The following is a description of a gene set: species: Homo sapiens Human Gene Set: GOCC_NUCLEAR_PROTEIN_CONTAINING_COMPLEX A stable assembly of two or more macromolecules, i.e. proteins, nucleic acids, carbohydrates or lipids, in which at least one component is a protein and the constituent parts function together in the nucleus., and this is the list of marker genes: PAXX, HNRNPA2B1, KAT8, GTF2A1, CDK13, INTS6, NELFE, RRP7BP, RNVU1-3, TESPA1, TAF1A, ANAPC2, FOS, CBX3, BCLAF3, ACTR8, RAD9A, MSH3, CSNK2A2, INTS14, CWC22, MLH1, GTF2E2, HNRNPDL, TAF9B, IRF9, THRA, TAF11L2, POLR1B, ORC5 (origin recognition complex subunit 5), DDX39B, GPKOW, CCNH, BASP1, POLR1A, OGT, TFPT, BOD1L1, POLR1E, PMS1, BRD9, DDX46, GLE1, COPS6, ORC1, POM121L2, MMS22L, PTGES3, WWOX, SSU72L4, DYNLL1, RBM47, ANAPC15, CSNK2A1, SF3B1, TAF11L3, NCR1, THRB, FOXH1, UIMC1, INO80D, TFIP11, MAFK, SMU1, GEMIN2, HSPA7, SNRPN, CLP1, FANCE, NXF2, ATRIP, MCM7, NXF5, GTF2H4, CSTF1, TOPBP1, TAF9, UTP6, TAF11L13, INTS3, ACTR6, EXOSC9 (exosome component 9), RFC3, IMP4, E2F5, RAN, HUS1, GPATCH1, JUNB, RNVU1-6, ATF3, CENPX, BAZ1A (bromodomain adjacent to zinc finger domain 1A), UXT, SSU72L2, ING2, PELP1, TRA2B, KMT2C, TCF15 (transcription factor 15), UBE2C, ATP23, UBE2S, NFYB, CDK2AP2, SMAD5, CEBPB (NCBI Gene Id 90277), SMARCAL1, U2SURP, CHMP1B, SHMT2, BCLAF1, LSM6, NXT1, MED27, MCRS1, JUND, POLD1, HEATR1, HNRNPF, DCAF1, TERC, GINS2, RGPD8, LEO1, RAMAC, JDP2, MSH6, CSNK2B, SMARCC2, CDC27, SSU72, HAVCR2, AMOT, HDAC1, AQR, PRMT5, ACTL6A, SLBP, PRPF40B, FZR1, TAF10, LSM3, SUV39H1, TERF1, MORF4L1, FAAP24, MIS18A, SYNE1, UTP4, ATF7, BPTF, SUN2, SLA (NCBI Gene Id 6503), PLCG1, SAMD11, ZNF217, ACD, MAD2L2, HDAC2 (NCBI Gene Id 3066), RBBP7, CPSF6, HSPA1A, UPF2, DHX40, DEK, THOC3, NUP54, ASCL3, ERCC6, SYNE4, SNIP1, SWI5, WEE2-AS1, POM121, ZNHIT1, SUPT5H, CPSF4, NUP205, DDX21, LUC7L, TAF11L12 (TATA-box binding protein associated factor 11 like 12), UPF1, YJU2, SYF2, RXRG, RAD9B, TUT1, BRCA2, NOC4L, HDAC6, BARD1, ATF5, INTS12, CPSF3, INO80, YY1AP1, LIG3, POLE3, TINF2, WAC, BCL11A, POLR2J, RFX5, UBAP2L, UBQLN4, KMT2A (NCBI Gene Id 79951), RBMY1J, MRNIP, SSU72L3, STAT6, GTF2A1L, RBMX, MX2, NKX2-5, POLR2A, THOC1, RBMX2, INTS7, STAT1, CHTF18, RBMY1D, CDC26, ATR, FLNA, TEAD2, POLR2H, UTY, RNU5D-1, SAP30, GRB2, TFDP1, CHMP4A, RNVU1-7, LGALS3, SSRP1, L3MBTL1, WBP4, HAND1, HDAC7 (histone deacetylase 7), RNVU1-4, JARID2, RGPD4, PPIH, DYDC1 (NCBI Gene Id 414183), TEN1, NIPBL, SNRNP200, CWF19L2, IPO5, SFR1 (SWI5 dependent homologous recombination repair protein 1), HDAC8, BACH2, NR5A2, BABAM2 (NCBI Gene Id 9577), XRCC1, MED20, TLE1, SLX4, ARFGEF1, SLU7, CECR2, EZH2, GATA4, ATF6, GCFC2, MIDEAS, RFXAP, RPP30, RBMY1B, MED7, SMAD3, COPS5, PBX1, RHEB, PAAF1, RPP40, AFF4, POLR3K, PRPF18, CHD3, TAF11L9, PHF5A, AHCTF1, SF3B2, RNU1-4, RYBP, RNU5F-1, HCFC1, SNRNP70, PHF19, YAP1, PNN, ASXL2, NUP88, MED15, WDR12, CEBPZ, PSMC5, SINHCAF, HNRNPH1, CSTF2T, INTS1, SF3B6, FLOT1, E2F4, RPA4, NOP14, TBL1XR1, MEPCE, CDC16, HDAC11, TAF1, RBM17, ZBTB7A, TRERF1, ELOA2, PPARGC1B, ERCC3, ACIN1, CREBZF, RPA3, AFF2, DNAJC17, SARNP, TAF2, BRCC3, SNRPD3, KDM3B, PHF21A, WDR6, XBP1, LSM2, EXOSC3, RFC2, C1D, GEMIN5, MED26 (NCBI Gene Id 9441), SRSF1, POLR2C, KPNB1, CDK2AP1, PPIL2, TERB1, TAF8, VDR, MYF6, RNU5A-1, TERT, PPIL1, RUVBL2, TXNL4A, RUNX1 (NCBI Gene Id 861), POLR3G, INTS11, DNTTIP1, PRIM2, SMARCD3, SNRNP35, BUB1B, MTA1, MED22, DEAF1, RNU5B-1, TDRD3, POLR3B, MAFB, CHTOP (chromatin target of PRMT1), RAD51, TET1, TBL1Y, SENP3, ASXL3, BICRAL, IMP3, GTF2H2, PRPF31, NUP155, SS18 (NCBI Gene Id 6760), SMARCA2, SNU13, REL, SF3A3, TCF7L1, NUDT21, MXI1, SKP1, TBL1X, RFC4, POLR3E, DQX1, RNF113A, BRMS1, GTF2E1, SSU72L5, GTF2B, PRPF19, THOC7, UBE2I, RAD1, HELB, TAF12-DT, TAF7, SNRPB, TAF4B, VPS4A, API5, RAD51B, CEBPD, CDK19, POLR2B, RXRA, CBFB (core-binding factor subunit beta), ZRSR2, SNRPD2 (NCBI Gene Id 6633), DDX19B, TBX15, SUN3, CDK7, BRIP1, DDX20, RNU4-1, RBMY1E, POLR1F, U2AF1, CPSF1, LIG4, CHMP4BP1, UBA2 (ubiquitin like modifier activating enzyme 2), KPNA3, POLR1H, CRIPT, NXF2B, POP1, MED18, SSU72L1, POLE2, BOD1, GTF2H5 (general transcription factor IIH subunit 5), POLR3A, RALY, TAF11L10, TAF3, SUPT6H, NUP107, RPP38, FANCL, THOC5, RNVU1-2A, APOBEC3F, POU4F1, NABP1, U2AF2, MAU2, NVL, NUP93, HLTF, KAT2A, ERI1, SENP2, EPB41L2, CHMP4B, FOSL2 (NCBI Gene Id 79579), NUP62, POLE4, SUN1, MMS19, ERCC1, HIPK2, HNRNPA1L3, ERCC8, COPS7A, XRCC4, MED12L, SETD1A, BCCIP, SIN3A, ZMAT5, LRWD1, INTS2, CACTIN (NCBI Gene Id 58536), TBX18, SUZ12, KANSL1, NUP188, NFE2L3 (NCBI Gene Id 9603), ANP32E, BCL9, POLR2I, IVNS1ABP, EIF4A3, WDR36, GRAP, RBM42, PRPF40A, DYDC2, INTS6L, SNUPN, MXD3, CETN3, ATF1, SMAD4, E2F1, NFATC2, PYM1, INIP, PYGO2 (pygopus family PHD finger 2), GTF2H1, CREB3, RGPD1, DDIT3, PRKRIP1, EXOSC2, MED17, RSF1, INO80E, TSEN34, ARID4A, ISY1, GNL3L, SNRNP27, ZNF335, PAF1, INTS13, CHMP5, ORC4, POLR2E, CTR9, NUP210, ATF6B, SNW1, INTS10, XAB2, CCDC9, SMARCA4, CFDP1, C9orf78, BCL7B, MED24, CBX4, TCF7, PHC2, CBX5, LEF1, SUN5, NFE2L2, TXNL4B, MAGOHB, HOXB9, SMAD1, SNRNP25, GTF2F2, NUP35, SF3B3, WRAP53, RGPD3 (NCBI Gene Id 692054), NEUROD1, LIN52, POU2F1, PEX2, MED10, BAP1 (BRCA1 associated deubiquitinase 1), SEH1L, CTC1, STAT5B, PPP2CA, APOBEC1, BCL9L, RGPD2, PCGF6, NOL6, FIP1L1, SUPT3H, RBMY1A1, DBF4B, A1CF, SUMO1, GTF2H2C_2, SMARCD2, THRAP3, MED21, FOXO3, PCID2, PRPF6, PTBP2, DPY30, CHD5, HDAC9, U2AF1L4, NUP42, ARID1B, RNVU1-17 (NCBI Gene Id 101954269), HINT1, TERF2IP, DR1, RBMY1F, FOSL1 (NCBI Gene Id 8061), RRP7A, TAF1L, ZFC3H1, PCF11, HDAC4, KAT7 (lysine acetyltransferase 7), CIRBP, BABAM1, COPS4, ERCC5, CDK12, SMAD2, PCGF2, ASCL4, DKC1, JMJD1C, KDM6B, NUP37 (nucleoporin 37), MAF, INTS8, ANAPC7, MPHOSPH10, DRAP1, ZFP42, CCNT2, NELFCD, HCFC2, RNF2, HNRNPA1L2, GINS4 (GINS complex subunit 4), MCM6, NHP2, IPO7, BACH1, DHX32, CWF19L1, RUVBL1, MVP, BRCA1, FRG1, ANXA2, CEBPE (NCBI Gene Id 1053), TENT4B (terminal nucleotidyltransferase 4B), SCML2, PCGF1, LSM10, POLD2, PAGR1, RAD51D, HEXIM1, ASCL1, CENPS, NUTF2, MFAP1, NFYA, KDM2B, RNU6-7, NDC1, PHF1, YJU2B, LUZP1, DMAP1, TCF4, CHMP1A, SEM1, SNRPGP15, DDX41, ATXN7 (NCBI Gene Id 6314), BCAS2, WDR18 (NCBI Gene Id 79082), PMS2, RNU2-1, ZCRB1, RARA, PRPF39, TAF5L, SIN3B, SMARCB1, WDR5, RTF1 (RTF1 homolog, Paf1/RNA polymerase II complex component), TAF1D, NOP10, CASC3, AKAP17A (A-kinase anchoring protein 17A), SLC5A8, GATAD2B, BCL11B, TAF5, NPAP1, E2F2, TEP1, STAT2, EXOSC8, TLE4, EAF1, MED29, EXOSC1, BATF3, CHD8, CETN2, SFPQ, RANBP17, EAF2 (ELL associated factor 2), RCOR1, GINS3, SRRM2, TCEA1, NCOA6 (NCBI Gene Id 23054), CBX7, LUC7L2, RBBP4, NUP210L, ANAPC16, NUP160, NELFA, PRIM1, CUL7, ELOA, POLR1G, POLR2J2, WDR82, HSPA1L, MED13L, RCOR2 (REST corepressor 2), CEBPA, CDC20B, R3HCC1L, MTA2, ZNFX1, POT1, POLR2D, SNRNP40, MED12, SUPT16H, TAF13, RNU5E-1, BMI1, PHC1, TCEA2, PCNA (proliferating cell nuclear antigen), CDKN1A, HR, ANAPC10, HSPA8, C17orf49, PRPF38B, ARID2, LAT, DPF2, MPND, LSM8, BMAL1, RPA1, SCNM1, LUC7L3, SNRNP48, DBF4, ING3, CHRAC1, RELB, XPC, ACTB, NCOR1, USP39, TAF6L, SMAD6, ENY2, MAD1L1, RBBP5, BOP1, VPS4B, RAE1, SYMPK, POLR3F, RNVU1-19, SCAF8, PLRG1, ZRSR2P1, CEBPG, MNAT1, SLX1B, KDM3A, TAF6, YY2 (YY2 transcription factor), RXRB (retinoid X receptor beta), DBP, BUD31, HNRNPU, MAGOH, POLR2L, KHDC4, MLLT1, EED, MED28, CDC40, CLMN, MED8, NR5A1, HNRNPA3, CXXC1, HSPA5, STAT5A (signal transducer and activator of transcription 5A), SUDS3, TADA3, TENT4A, SNRPB2, AMOTL1, RBM48, CHMP2B, KDM6A, RPA2, PRP4K, RNVU1-8, TCF12, CHD4, DGCR8, PCGF3, PASD1, GPS1, RBM5, LIN54, WDR5B, THOC2, TBPL1, INTS5, POP7, TRIM28, GTF2H3, ATF4, RBM41 (RNA binding motif protein 41, NCBI Gene Id 80171), TMOD1, NUP133, NOC2L (NOC2 like nucleolar associated transcriptional repressor), RCOR3, KMT2D (lysine methyltransferase 2D), INTS4, INO80B, MAD2L1, CSTF2, EZH1, CRY2, BCL7C, TIMELESS, RNF113B, NUP58, TAF11L4, POM121C, ICE2, ZMAT2, XRCC5, ICE1, CREM, BICD2, AFF3, MBD2, ARID4B, PHC3, ABRAXAS2, CBX8, SS18L1, ASCL2, LSM11, RNU6-9, DPF3, STAT4, SMARCD1, ELOF1, BIN1, CBX2 (NCBI Gene Id 876), MTREX, ING1, NCKIPSD, INTS15, POLR1D, EPOP, TAF11L7, ELL2 (NCBI Gene Id 22936), SMG6, MEN1, COPS2, WDR33, COPS3, EXOSC6, MGA, FANCG, KAT5, PIP5K1A, CWC15, NPAS2, NUP85, PDCD7, PARP11, JUN, TSEN54, ABRAXAS1, RAD50, WDR83, RUNX3, AEBP2, COPS9, BCOR, XRCC3, CHMP2A, CPSF7, BAZ2A, TRA2A, TEAD1, RNU6-1, AAR2, CHMP7, NXF1, MYBL2, HDAC10, PPP2R1A (protein phosphatase 2 scaffold subunit Aalpha), BMAL2, KDM1A, SMNDC1, FANCA, MYH9, KPNA1, ANAPC11, UTP18, ELP4, MED19, LSM7, RBM3, TAF1B, POLR2F, SSU72L6, PRPF38A, ETV3, CBX6, SAGE2P, DOCK7, CAMSAP3, RBMXL1, FANCC, RNVU1-1, MED16, RELA (RELA proto-oncogene, NF-kB subunit), E2F8, STN1, LIN37, MYZAP, SREK1, SNRPA1, PAXIP1, CHMP3, NFIL3, SMARCA1, SMARCA5, CCNK, SAP30L, EIF5A, RANBP2, FAAP100, BRMS1L, ZC3HC1, HIF1A, BRD7, DNMT3L, CDC45, DDX42, TRRAP, ANAPC4, HNRNPM, NCOA2, ZC3H3, RGPD6, PPIE, GTF2A2, ERCC2, NUFIP1, SNRPE, BUB3, BCL7A, SMG5, MPHOSPH6, MED9, SYNE2, E2F7, PRPF3, MBD3, DIS3, TONSL, AHR, RBM8A, SP100, TNKS, UVRAG, SATB2, NR1H4, POLA2, ACTR5, BATF2, MAFG (NCBI Gene Id 84797), PHF10 (NCBI Gene Id 55274), ELP2, PRPF4, LDB1, NUP43, MAX, RFC5, TCF3, KASH5, MXD1, SETD5, RNU4-2, NPIPA1, BAHD1, XPA, CREB1, TAF11L14, EFTUD2, COPS8, NUP153, EXOSC4, MED6, NFRKB, CPSF2, ATXN7L3, HDAC5, RNVU1-15, ARID1A, RPP21, ANAPC13, SYNE3, ANAPC1, GINS1, MRE11, CCNT1, THEMIS, MCM3, CCDC12, ADAR, HLF, RBM28, TAF11L6, POLR3GL, HNRNPC, MED31, MED4, TAF12, RNPS1, ELOC, DHX8, RGPD5, E2F6, PRKDC, NABP2, ANAPC5, DDX5, CSNK1A1, SMAD7, KMT2B, S100A10, ZNF830, SEC13, MYB, EP400, SIRT2, HNRNPAB, JUP, XIST, POLR2M, HYAL2, ZCCHC8, NOL11, NFYC, PRDM4, CDC20, POM121B, AGFG1, CRX, SAE1, TCF7L2, BUD13, PHF12 (NCBI Gene Id 57649), SRCAP, HMGXB4, CWC25, NAT10 (N-acetyltransferase 10), WDR3, CSTF3, BRD8, DHX35, KMT2E, MED25, RNU11, ORC2, POLR1C, GTF2H2C, XPO7, HMGA1, CDC23, CDK8, THOC6, COPS7B, SAP18, POLR2G, DPF1, BRD1, SNRPA, CD2BP2, DHX15, CPSF4L, MYO1C, SYNCRIP, CHTF8, LSM5, SRRM1, ORC3, ASCL5, TAF1C, PWP2, TEX10, HSP90AB1, CWC27, SF3A1, SF3B5, ARMC7, HNRNPH3, CTNNB1, POLR2K, CTNNBIP1, RNU6ATAC, ELL, IK, HDAC3, HNRNPK, SAMD7, FANCM, TENT2, PES1, HTATSF1, CDC73, RNVU1-14, PABPC1, XPO4, SKIC8, FAAP20, SUPT4H1, MSH2, NUP214, WDR74, SNRPC, NUP62CL, ZNF541, NFE2, ARNT (NCBI Gene Id 405), POP5, ERCC4, RPS3, TFDP2, MAFF, EXOSC10, ORC6, POLR3D, SART3, MYC, EXOSC5, POLE, BAZ1B, ASXL1, NR1H2, YBX1, SPAG4, E2F3, TSEN2, UPF3A, GTF2F1, TIPIN, CLNS1A, SETD1B, RNPC3 (RNA binding region (RNP1, RRM) containing 3), TAF11, SUGP1 (NCBI Gene Id 57794), CRCP, DHX16, POLD4, MCM5, RNU4ATAC (RNA, U4atac small nuclear), CDK9, BATF, NBN, NR1H3, DROSHA, DSCC1, CLOCK, TRIM37, NUP98, DHX38, SMAD9, TAF7L, FANCF, NELFB, MED30, HNRNPR, RAD23B, SLX1A, ASH2L, ACTL6B, RNMT, XRCC2, KPNA4, TAF4, RAMACL, MCM3AP, NUP50, TAF11L8, ELL3, HNRNPA1, RERE, TPR, NXT2, AAAS, POLR3H, XRCC6, PPP1R8, LSM4, ESS2, MLLT3, SMARCC1, SNRPF, TGS1, PRPF8, MYF5, LMO4, DDX23, TTF2, SART1, YY1, MED1, SMG7, CRNKL1, ELOB, NXF3, CCNC, RFXANK, MED14, SMARCE1, MED11, SF3B4, LARP7, MED23, TAF11L11, PPIL3, GATAD2A, MTA3, POLA1, ZCCHC7, USP22, NCOA1, PCGF5, TBP, CDC5L, SAP130, POU2AF1, ZC3H8, TUFT1, NHEJ1, SNRPG, POLD3, HUS1B, MCM4, CTNNBL1, GAR1, CHMP6, FANCB, MYBBP1A, PER2, INO80C, SF1, RAD51C, EXOSC7, MTF2 (NCBI Gene Id 22823), TERF2, NFKB1, MED13, NCL, POLR3C, MCM2, GEMIN4, RANBP1, SF3A2, LAS1L, RN7SK (NCBI Gene Id 6028), TSSC4, UPF3B, RBBP8, APOBEC3G, INTS9, RBM22, HSPA6, RING1, RANGAP1, XPOT, TLE3, ATF2, SAGE1, ALYREF, RBM44, POLR2J3, RRP8, NONO, PBRM1, CHMP4C, SIRT1, PPARG, MECOM, UCHL5, ZC3H11A, BICRA, ADNP, NRIP1, BIRC5, AFF1, PPWD1, ESRRB, PHF20, RB1, STAT3, SNRPD1